Given this list of marker genes LEP, HSD3B1, CGA, CGB3, LHB, TFPI, XAGE3, here is a description of the gene set: from publication Korkola JE, Houldsworth J, Dobrzynski D, Olshen AB, Reuter VE, Bosl GJ, Chaganti RS (PMID 15870693) Genes predicting the choriocarcinoma (CC) of nonseminomatous male germ cell tumors (NSGCT). Male adult germ cell tumors (GCTs) comprise two major histologic groups: seminomas and nonseminomas. Nonseminomatous GCTs (NSGCTs) can be further divided into embryonal carcinoma (EC), teratoma (T), yolk sac tumor (YS), and choriocarcinoma (CC) on the basis of the lineage differentiation that they exhibit. NSGCTs frequently present as mixed tumors consisting of two or more histological subtypes, often limiting correlative studies of clinical and molecular features to histology. We sought to develop a molecular classifier that could predict the predominant histologic subtype within mixed NSGCT tumor samples. The expression profiles of 84 NSGCTs (42 pure and 42 mixed) and normal age-matched testes were obtained using Affymetrix microarrays. Using prediction analysis for microarrays, we identified 146 transcripts that classified the histology of pure NSGCTs samples with 93% accuracy. When applied to mixed NSGCTs, the classifier predicted a histology that was consistent with one of the reported components in 93% of cases. Among the predictive transcripts were CGB (high in CC), LCN2 (high in T), BMP2 (high in YS), and POU5F1 (high in EC). Thus, the expression-based classifier accurately assigned a single predominant histology to mixed NSGCTs, and identified transcripts differentially expressed between histologic components with relevance to NSGCT differentiation. studied in species Homo sapiens Human Gene Set: KORKOLA_CHORIOCARCINOMA